Given this list of marker genes Gata5, Nbl1, Tnfaip6, Sfrp2, Tcf7l2, Bmp2, Nog, Tob1, Acvr2a, Fst, Rgma, Gdf6, Fzd1, Nfia, Usp15, Bmp6, Pelo, Rbpms2, Mtmr4, Tmem53, Fbxl15, Tbx20, Hjv, Rgmb, Abl1 (c-abl oncogene 1, non-receptor tyrosine kinase), Dlx1, Hoxa13, Numa1, Smpd3, Kcnd3, Bmpr1a, Mir23a (microRNA 23a), Vwc2, Kdr, Lrp2, Mir147, Ror2, Bmp8b, Gpr155, Ext1, Scube3, Elapor2, Mirlet7a-1, Htra1, Mirlet7b, Comp, Ark2c, Prmt1, Gdf3, Bmncr, Chrdl2, Foxd1 (forkhead box D1), Phox2b, Gdf2, Eng (NCBI Gene Id 99055), Acvr2b, Sox9, Bglap, Mir122, Lef1, Cer1, Chrd, Mir16-1, Hes1, Bmp7, Dlx3, Tgfbr3, Dand5, Hfe, Crb2, Fkbp8, Notch1, Msx1, Adamts12, Tgfbr1, Bambi, Twsg1, Bmpr1b, Mir675, Heyl, Tfap2b, Tmem119, Fstl4, Mirlet7d, Fbn1, Ecsit, Sfrp1, Amhr2 (anti-Mullerian hormone type 2 receptor), Ube2o, Vsir, Pparg, Zcchc12, Smad4, Ddx5, Atf2, Acvrl1, Skor1, Slc39a5, Skil, Id1, Kcp, Gata4, Bmp10, Trim33, Ppm1a, Grem1, Egr1, Sost, Skor2, Smurf1, Lemd2, Cdh5, Etv2, Chrdl1, Nanog, Fstl5, Pdcd4, Ilk, Lemd3, Vstm2a, Smad9, Tgfbr2, Hes5, Smad7, Cav1, Gpc3, Alpi, Zfp128, Grem2, Scx, Gdf7, Sorl1, Mapk3 (NCBI Gene Id 26417), Acvr1, Bmp5, Nfix, Itga3, Bmper, Dkk1, Crim1, Ngly1, Runx2, Wnt3a (wingless-type MMTV integration site family, member 3A, NCBI Gene Id 22416), Smad2, Mir125a, Smad5, Smad1, Fstl3, Mirlet7f-2, Megf8, Spart, Hipk2, Dsg4 (desmoglein 4), Sfrp4 (secreted frizzled-related protein 4), Smad6, Wnt5a (wingless-type MMTV integration site family, member 5A), Gdf5, Rbpj, Usp9x (NCBI Gene Id 77016), Gata6, Ski, Mirlet7f-1, Msx2, Tmprss6, Bmpr2, Erfe, Htra3, Neo1, Notch2, Ctdspl2, Sulf1, Bmp4, Spint1, Dlx5, Sox11, Mir210, Fstl1, Zfp423, Sostdc1, Smurf2, Gata3, Wnt1, Col2a1, Acvr1b, Ccn1, Vwc2l, Tmem100, Fam83g, Hivep1, Mir329, Acvr1c, Adamts7, here is a description of the gene set: Mouse Gene Set: GOBP_RESPONSE_TO_BMP species: Mus musculus Any process that results in a change in state or activity of a cell or an organism (in terms of movement, secretion, enzyme production, gene expression, etc.) as a result of a bone morphogenetic protein (BMP) stimulus.